Given this list of marker genes GBA1LP, ICAM3, SBNO2, SIL1, UFC1, HGSNAT, PCTP, MARCHF2, TMEM104, HSPB1, OAS1, NXT2, SLC25A13, HFE, CYTH1, TSPAN31, BABAM2, MAN1B1, C22orf46P, LAMTOR2, MEAK7, DNALI1, CCS, ACADS, FOXP3, SLC48A1, CASP4, IBSP, ODF2, PDLIM5, MCUB, CCDC92, IQGAP1, MAPK12, C1orf35, ENC1, MED8, GUK1, GSTK1, GGA2, MYO1F, FN1, CD151, ZNF668, CDKN2C, FBXO11, ANXA2P2 (annexin A2 pseudogene 2), BCL7B, TP53TG1, BLVRB, PEX10, CCHCR1, TMED10, CDK11B, RPL23, DOCK9, MAGOHB, DXO, ZSWIM8-AS1, TEDC2, INPP5B, KCTD17, VPS33B, PHF1, LRRC14, RINT1, CRIP2, IGHV5-51, HDAC1, TAF12, ADAM15 (NCBI Gene Id 8751), PTHLH, PPP4C, HHAT, PPIEL (peptidylprolyl isomerase E like (pseudogene)), TBX1, BCAP31, STYXL1, MSRB1, IZUMO4, USE1, TSPAN8, KLRF1, here is a description of the gene set: BACKGROUND: Genes that are overexpressed in multidrug-resistant neuroblastomas relative to drug-sensitive neuroblastomas may provide targets for modulating drug resistance. METHODS: We used microarrays to compare the gene expression profile of two drug-sensitive neuroblastoma cell lines with that of three multidrug-resistant neuroblastoma cell lines. RNA expression of selected overexpressed genes was quantified in 17 neuroblastoma cell lines by reverse transcription-polymerase chain reaction (RT-PCR). Small-interfering RNAs (siRNAs) were used for silencing gene expression. Cytotoxicity of melphalan, carboplatin, etoposide, and vincristine and cytotoxic synergy (expressed as combination index calculated by CalcuSyn software, where combination index < 1 indicates synergy and > 1 indicates antagonism) were measured in cell lines with a fluorescence-based assay of cell viability. All statistical tests were two-sided. RESULTS: A total of genes were overexpressed in the multidrug-resistant cell lines relative to the drug-sensitive cell lines. Nine genes were selected for RT-PCR analysis, of which four displayed higher mRNA expression in the multidrug-resistant lines than in the drug-sensitive lines: histone deacetylase 1 (HDAC1; 2.3-fold difference, 95% confidence interval = 1.0-fold to 3.5-fold, P =.025), nuclear transport factor 2-like export factor (4.2-fold difference, 95% CI = 1.7-fold to 7.6-fold, P =.0018), heat shock 27-kDa protein 1 (2.5-fold difference, 95% CI = 1.0-fold to 87.7-fold, P =.028), and TAF12 RNA polymerase II, TATA box-binding protein-associated factor, 20 kDa (2.2-fold, 95% CI = 0.9-fold to 6.0-fold, P =.051). siRNA knockdown of HDAC1 gene expression sensitized CHLA-136 neuroblastoma cells to etoposide up to fivefold relative to the parental cell line or scrambled siRNA-transfected cells (P<.001). Cytotoxicity of the histone deacetylase inhibitor depsipeptide was tested in combination with melphalan, carboplatin, etoposide, or vincristine in five multidrug-resistant neuroblastoma cell lines, and synergistic cytotoxicity was demonstrated at a 90% cell kill of treated cells (combination index < 0.8) in all cell lines. CONCLUSION: High HDAC1 mRNA expression was associated with multidrug resistance in neuroblastoma cell lines, and inhibition of HDAC1 expression or activity enhanced the cytotoxicity of chemotherapeutic drugs in multidrug-resistant neuroblastoma cell lines. Thus, HDAC1 is a potential therapeutic target in multidrug-resistant neuroblastoma. studied in species Homo sapiens Genes up-regulated in multiple drug resistant neuroblastoma cell lines. Human Gene Set: KESHELAVA_MULTIPLE_DRUG_RESISTANCE from publication Keshelava N, Davicioni E, Wan Z, Ji L, Sposto R, Triche TJ, Reynolds CP (PMID 17623797)